The following is a description of a gene set: This event has been computationally inferred from an event that has been demonstrated in another species.<p>The inference is based on the homology mapping from PANTHER. Briefly, reactions for which all involved PhysicalEntities (in input, output and catalyst) have a mapped orthologue/paralogue (for complexes at least 75% of components must have a mapping) are inferred to the other species. electronically inferred by orthology from the curated human pathway Reactome Pathway: Formation of apoptosome studied in species Mus musculus part of: Cytochrome c-mediated apoptotic response, and this is the list of marker genes: Aven (apoptosis, caspase activation inhibitor), Mapk3, Casp9, Apip, Cycs